The following is a description of a gene set: Human Gene Set: SALVADOR_MARTIN_PEDIATRIC_TBD_ANTI_TNF_THERAPY_NONRESPONDER_POST_TREATMENT_UP Genes upregulated in anti-TNF therapy non-responders vs. responders after two weeks of anti-TNF therapy from publication Salvador-Martín S, Kaczmarczyk B, Álvarez R, Navas-López VM, Gallego-Fernández C, Moreno-Álvarez A, Solar-Boga A, Sánchez C, Tolin M, Velasco M, Muñoz-Codoceo R, Rodriguez-Martinez A, Vayo CA, Bossacoma F, Pujol-Muncunill G, Fobelo MJ, Millán-Jiménez A, Magallares L, Martínez-Ojinaga E, Loverdos I, Eizaguirre FJ, Blanca-García JA, Clemente S, García-Romero R, Merino-Bohórquez V, González de Caldas R, Vázquez E, Dopazo A, Sanjurjo-Sáez M, López-Fernández LA (PMID 33429950) Background: Up to 30% of patients with pediatric inflammatory bowel disease (IBD) do not respond to anti-Tumor Necrosis Factor (anti-TNF) therapy. The aim of this study was to identify pharmacogenomic markers that predict early response to anti-TNF drugs in pediatric patients with IBD. Methods: An observational, longitudinal, prospective cohort study was conducted. The study population comprised 38 patients with IBD aged < 18 years who started treatment with infliximab or adalimumab (29 responders and nine non-responders). Whole gene expression profiles from total RNA isolated from whole blood samples of six responders and six non-responders taken before administration of the biologic and after two weeks of therapy were analyzed using next-generation RNA sequencing. The expression of six selected genes was measured for purposes of validation in all of the 38 patients recruited using qPCR. Results: Genes were differentially expressed in non-responders and responders (32 before initiation of treatment and 44 after two weeks, Log2FC (Fold change) >0.6 or <_0.6 and p value < 0.05). After validation, FCGR1A, FCGR1B, and GBP1 were overexpressed in non-responders two weeks after initiation of anti-TNF treatment (Log2FC 1.05, 1.21, and 1.08, respectively, p value < 0.05). Conclusion: Expression of the FCGR1A, FCGR1B, and GBP1 genes is a pharmacogenomic biomarker of early response to anti-TNF agents in pediatric IBD. studied in species Homo sapiens, and this is the list of marker genes: BATF2, UBE2L6, DNAJC25-GNG10, IGFLR1, HLA-H, APOL6, FCGR1CP, APOL2, FCGR1BP, TYMP, IRF1, GBP2, RHBDF2, MYOM2, DHRS9, GBP5, GBP1, PLAAT4, ANKRD22, GZMA, SERPING1, IL1B, FCGR1A, CIMAP1B, HLA-C, SECTM1